Given this list of marker genes CYP2C9, RRM1, RRM2, VKORC1, CYP3A4, CYP2C8, XDH, RRM2B, ACOX2, VKORC1L1, CYP1A2, here is a description of the gene set: Catalysis of an oxidation-reduction (redox) reaction in which a CH2 group acts as a hydrogen or electron donor and reduces a hydrogen or electron acceptor. species: Homo sapiens Human Gene Set: GOMF_OXIDOREDUCTASE_ACTIVITY_ACTING_ON_CH_OR_CH2_GROUPS